Given this list of marker genes KIR2DL4, CD160, HLA-G, RAET1G, IL21, CLNK, HLA-F, HLA-E, CD226 (NCBI Gene Id 10666), here is a description of the gene set: species: Homo sapiens Human Gene Set: GOBP_POSITIVE_REGULATION_OF_NATURAL_KILLER_CELL_CYTOKINE_PRODUCTION Any process that activates or increases the frequency, rate, or extent of natural killer cell cytokine production.